The following is a description of a gene set: species: Homo sapiens from publication van den Biggelaar AH, Pomat W, Bosco A, Phuanukoonnon S, Devitt CJ, Nadal-Sims MA, Siba PM, Richmond PC, Lehmann D, Holt PG (PMID 21645573) Genes up-regulated in peripheral blood mononuclear cell stimulated vs unstimulated in infants (9m) (neonatal) after exposure to Prevnar (USA), time point 8M Human Gene Set: VAN_DEN_BIGGELAAR_PBMC_PREVNAR_9MO_INFANT_STIMULATED_VS_UNSTIMULATED_8MO_UP Concerns about the risk of inducing immune deviation-associated neonatal tolerance as described in mice have restricted the widespread adoption of neonatal vaccination. The aim of this study was to demonstrate the immunological feasibility of neonatal pneumococcal conjugate vaccination (PCV) which could potentially protect high-risk infants in resource poor countries against severe pneumococcal disease and mortality in the early critical period of life. Papua New Guinean infants were randomized to be vaccinated with the 7-valent PCV (7vPCV) at birth, 1 and 2 months (neonatal group, n=104) or at 1, 2 and 3 months of age (infant group, n=105), or to not receive 7vPCV at all (control group, n=109). Analysis of vaccine responses at 3 and 9 months of age demonstrated persistently higher type-1 (IFN-gamma) and type-2 (IL-5 and IL-13) T-cell responses to the protein carrier CRM(197) and IgG antibody titres to 7vPCV serotypes in children vaccinated with 7vPCV according to either schedule as compared to unvaccinated children. In a comprehensive immuno-phenotypic analysis at 9 months of age, no differences in the quantity or quality of vaccine-specific T cell memory responses were found between neonatal vaccinations versus children given their first PCV dose at one month. Hospitalization rates in the first month of life did not differ between children vaccinated with PCV at birth or not. These findings demonstrate that neonatal 7vPCV vaccination is safe and not associated with immunological tolerance. Neonatal immunisation schedules should therefore be considered in high-risk areas where this may result in improved vaccine coverage and the earliest possible protection against pneumococcal disease and death., and this is the list of marker genes: AQP7, TEDC2, BUB1B, EXO1, H2AC4, PSG5, CIT, CD274, DIAPH3, ZBTB32, IL18R1 (interleukin 18 receptor 1), FGL2, AICDA, ZBED2, CENPF, TNFSF4, AURKA, NEK2, PRC1, NUF2, E2F8, C1S, H3C7 (H3 clustered histone 7, NCBI Gene Id 8968), TRIP13, CDK1, ELOA3P, ELOVL6, H2AC14, HTR1A, CDC45, IL3, RAB19, H2BC13, NUSAP1, H2AC13, ITGA2, IL12RB2, CDCA2, EEF2KMT, POGLUT2, CLSPN, OR2T8, H3C12, AURKB, H2AC16, MLC1, RP1L1, RAD51 (RAD51 recombinase), APOL4, NEIL3, TICRR, IDI2, FAM90A1, IL9, IFNG (NCBI Gene Id 3458), KIF15, RHO, SERPING1, H3C8, SHC4, SIX1 (NCBI Gene Id 6495), GBP5, FOXM1, H2BC7 (H2B clustered histone 7), CHAF1B, SSX4, CKAP2L, GNLY, GBP6, KIF14, PBK, OSM, MTFR2, DUSP4, MCM4, OR6B3, KNL1, GBP4, ARHGAP11A, PCLAF, ARHGEF39